Given this list of marker genes TDRD12, SLC7A7, ITGAM, CCL2, CD84, CTSS (NCBI Gene Id 50653), EVI2A, TACC1, SMC2, CACNA2D3, SLC15A3, SRSF11, ZFP36L2, CTSZ, NECTIN3, ARPC1B, PIP4K2A, SLC38A6, TYROBP, BCAT1, PLA2G2A, SRGN, TLR7, FCER1G, FKBP1A, FPR3, CALU, DCLK1, GPSM3, COLEC12, LCP1, CTSB, SDC2, SERPINA1, LYZ, THY1, ABI3BP, RHOJ, TPK1, CCR1, AP1S2, IKZF1, SERPINA3, DDOST, TFEC, EVI2B, CD33, GLIPR1, HMOX1, PIK3AP1, C16orf54, CLEC12A (NCBI Gene Id 160364), LGMN, CAPRIN1, SSR2, EFEMP1, RAB32, PAPSS2, CD163 (NCBI Gene Id 9332), VSIG4, CD180, CYBB, CENPH (centromere protein H), CALHM6, TIMP1, MS4A6A, ARHGAP18, NAGA, ZNF567, C3AR1, C1RL, IGF2BP3, GZMK, IL13RA1, ATP11A, POLR1D, PTGER4, SAMSN1, NPL, CD86, HAVCR2, INHBC, CLIC2, CX3CR1, AOX1, ACP5, AIF1, SH2B3, LIPC, CLEC7A, B3GNT7, NID1, PTP4A2 (NCBI Gene Id 8073), EPB41L3, PLXDC1, SASH3, MYO5A, CLU, CPVL, HGF, LY86, DAB2, LIPA, MARCKS, IGSF6, LILRB2, IKBIP, OSTC, MPEG1, TLR8, here is a description of the gene set: from publication Patel NP, Vukmanovic-Stejic M, Suarez-Farinas M, Chambers ES, Sandhu D, Fuentes-Duculan J, Mabbott NA, Rustin MHA, Krueger J, Akbar AN (PMID 30247603) Background: The live attenuated vaccine Zostavax was developed to prevent varicella zoster virus (VZV) reactivation that causes herpes zoster (shingles) in older humans. However, the impact of vaccination on the cutaneous response to VZV is not known. Methods: We investigated the response to intradermal VZV antigen challenge before and after Zostavax vaccination in participants > 70 years of age by immunohistological and transcriptomic analyses of skin biopsy specimens collected from the challenge site. Results: Vaccination increased the proportion of VZV-specific CD4+ T cells in the blood and promoted the accumulation of both CD4+ and CD8+ T cells in the skin after VZV antigen challenge. However, Zostavax did not alter the proportion of resident memory T cells (CD4+ and CD8+) or CD4+Foxp3+ regulatory T cells in unchallenged skin. After vaccination, there was increased cutaneous T-cell proliferation at the challenge site and also increased recruitment of T cells from the blood, as indicated by an elevated T-cell migratory gene signature. CD8+ T-cell-associated functional genes were also highly induced in the skin after vaccination. Conclusion: Zostavax vaccination does not alter the abundance of cutaneous resident memory T cells but instead increases the recruitment of VZV-specific T cells from the blood and enhances T-cell activation, particularly cells of the CD8+ subset, in the skin after VZV antigen challenge. Genes up-regulated in skin of body 3d vs 0hr in adults (70-93) (VZV challenge) after exposure to Zostavax, time point 3D Human Gene Set: PATEL_SKIN_OF_BODY_ZOSTAVAX_AGE_70_93YO_VZV_CHALLENGE_3DY_UP species: Homo sapiens